The following is a description of a gene set: Mouse Gene Set: MIR_1224_3P Genes predicted to be targets of miRBase v22 microRNA mmu_miR_1224_3p in miRDB v6.0 with MirTarget v4 prediction scores > 80 (high confidence targets). from publication Chen Y, Wang X (PMID 31504780) studied in species Mus musculus, and this is the list of marker genes: Ets1, Cyb561d1, Sort1, Nmnat2 (nicotinamide nucleotide adenylyltransferase 2), Rsrp1, Rab6b, Mex3a, Cd200r4, Slc31a1 (solute carrier family 31, member 1), Fibcd1, Polr3h, Tmem72, Wdr82, Trp53i11, Slc35a4, Upb1, Tnrc6b, Hectd1, Mgat3, Arfgap3, Ago1, Pclaf, Elk4, Otx1, Ptbp2, Kpna6, Cdh8, Prx, Mindy2, Rimklb, Otud7b, Ddx52, Atf6b, Nxph4, Timm17a, Rabgap1l, Marchf2, Ptgfrn, Apln